The following is a description of a gene set: Mouse Gene Set: MIKKELSEN_NPC_WITH_LCP_H3K27ME3 We report the application of single-molecule-based sequencing technology for high-throughput profiling of histone modifications in mammalian cells. By obtaining over four billion bases of sequence from chromatin immunoprecipitated DNA, we generated genome-wide chromatin-state maps of mouse embryonic stem cells, neural progenitor cells and embryonic fibroblasts. We find that lysine 4 and lysine 27 trimethylation effectively discriminates genes that are expressed, poised for expression, or stably repressed, and therefore reflect cell state and lineage potential. Lysine 36 trimethylation marks primary coding and non-coding transcripts, facilitating gene annotation. Trimethylation of lysine 9 and lysine 20 is detected at satellite, telomeric and active long-terminal repeats, and can spread into proximal unique sequences. Lysine 4 and lysine 9 trimethylation marks imprinting control regions. Finally, we show that chromatin state can be read in an allele-specific manner by using single nucleotide polymorphisms. This study provides a framework for the application of comprehensive chromatin profiling towards characterization of diverse mammalian cell populations. Genes with low-CpG-density promoters (LCP) bearing histone H3 trimethylation mark at K27 in neural progenitor cells (NPC). species: Mus musculus from publication Mikkelsen TS, Ku M, Jaffe DB, Issac B, Lieberman E, Giannoukos G, Alvarez P, Brockman W, Kim TK, Koche RP, Lee W, Mendenhall E, O'Donovan A, Presser A, Russ C, Xie X, Meissner A, Wernig M, Jaenisch R, Nusbaum C, Lander ES, Bernstein BE (PMID 17603471), and this is the list of marker genes: Ccn5, Rp1, Cysrt1, Adgre4, Krt77, Ccm2l, Prelp, Gsdma2, Cstdc2, Blk